Given this list of marker genes IGHV3-43, IGLV3-19, IGKV3D-11, IGLV2-11, IGLV1-47, IGKV1-37, IGKV1-17, IGHV4-4, IGKV1D-37, IGKV6D-41, VPREB3, IGHG3, IGLV3-21, IGLC6, IGKV6-21, IGLV3-22, IGHV3-53, IGLV3-32 (NCBI Gene Id 28787), IGHV1-45, IGLV9-49, IGLV3-25, IGLC3, IGKV2-40, IGHE, IGKV1D-33 (NCBI Gene Id 652694), IGHV1-69, IGHV4-39, IGHV4-34, IGKV1-8, IGHD1-1, IGLV5-48, JCHAIN, IGHM, IGHG1, IGHV3-38, IGHV2-70D, IGKV6D-21, PIGR, IGHV3-64, IGLV3-12, IGHV1-24, IGLV1-44, CD79A, IGKV1-27, IGLV5-37, IGHV1-3, IGKV2-24, IGKV2-30, IGHJ1, SYK, IGKV1-13, TRAV19, IGHV5-51, CD79B, IGHV3-20, IGHV3-23, TRAV2 (T cell receptor alpha variable 2), IGLV4-69, IGKV1D-43, IGLC7, IGKV1-5, IGKV1-39, LIME1, IGHV4-59, IGKC (immunoglobulin kappa constant), IGLL1, IGLV3-1, IGHV2-26, IGLV2-14, IGKV1D-12, IGHD, IGKV1D-39, IGKV2-28, TRAV38-1, IGHV3-21, IGHV2-5, IGKV3D-7, IGKV3-15, IGHV3-48, TRAV38-2DV8, TRAV14DV4, IGKV2D-28, IGLV2-18, IGHV1-69-2, IGKV2D-30, IGHV3-66, IGLV10-54, IGLV2-8, IGLV2-23, IGHV1-18, IGLV6-57, TRDV1, IGLV1-36, IGKV2D-29, IGLV3-16, IGLV11-55, IGLV4-3, TRDV3, IGLV1-51, IGHV3-49, IGKV3-7, IGHV3-16, IGHV3-7, IGLV3-27, IGKV1D-17, IGKV1-12, IGHV3-30, IGLV1-50, IGHV3-73, IGKV5-2, IGLV4-60, IGHV3-11, IGHV3-74, IGHV1-69D, IGHG4, IGHV4-28, IGHV7-81, VPREB1, IGKV1D-42, IGHV8-51-1, IGHV2-70, IGLC1, IGHV3-15 (NCBI Gene Id 28448), IGLV7-46, IGLC2, IGKV4-1, IGHV3-64D, IGLJ1, IGKV1D-13, IGHV3-72, IGKV3D-20, IGKV3D-15, IGKV3-20, IGHA1, IGKJ1, IGKV1-16, IGHV6-1, IGHV3-35, IGKV1-9, IGKV1-6 (NCBI Gene Id 28943), IGHG2, IGHV5-10-1, IGLV3-9, IGLV1-40, IGKV2D-26, IGHV3-33, IGLV7-43, IGHV3-13, IGLL5, IGHA2, IGLV8-61, IGLV3-10, IGHV4-31 (NCBI Gene Id 652848), IGKV2-29, IGKV1D-8, IGLV5-52, IGHV1-58, IGHV4-61, IGLV5-45, IGLV2-33, IGKV2D-24, IGHV7-4-1, here is a description of the gene set: A protein complex that in its canonical form is composed of two identical immunoglobulin heavy chains and two identical immunoglobulin light chains, held together by disulfide bonds and sometimes complexed with additional proteins. An immunoglobulin complex may be embedded in the plasma membrane or present in the extracellular space, in mucosal areas or other tissues, or circulating in the blood or lymph. Human Gene Set: GOCC_IMMUNOGLOBULIN_COMPLEX studied in species Homo sapiens